The following is a description of a gene set: RUNX3 regulates CDKN1A transcription studied in species Homo sapiens Human Gene Set: REACTOME_RUNX3_REGULATES_CDKN1A_TRANSCRIPTION, and this is the list of marker genes: RUNX3, TGFB1, SMAD4 (SMAD family member 4), CDKN1A, TP53, ZFHX3, SMAD3